The following is a description of a gene set: studied in species Mus musculus This event has been computationally inferred from an event that has been demonstrated in another species.<p>The inference is based on the homology mapping from PANTHER. Briefly, reactions for which all involved PhysicalEntities (in input, output and catalyst) have a mapped orthologue/paralogue (for complexes at least 75% of components must have a mapping) are inferred to the other species. electronically inferred by orthology from the curated human pathway Reactome Pathway: RUNX3 regulates CDKN1A transcription part of: Transcriptional regulation by RUNX3, and this is the list of marker genes: Smad3, Tgfb1 (NCBI Gene Id 21803), Trp53